Given this list of marker genes Rps6kb1, Actn3, Dll1, Igf2, Tll2, Mstn, Mtm1, Adrb2, here is a description of the gene set: Any process that modulates the frequency, rate or extent of skeletal muscle growth. species: Mus musculus Mouse Gene Set: GOBP_REGULATION_OF_SKELETAL_MUSCLE_TISSUE_GROWTH